The following is a description of a gene set: A better understanding of the molecular effects of aging in the brain may help to reveal important aspects of organismal aging, as well as processes that lead to age-related brain dysfunction. In this study, we have examined differences in gene expression in the hypothalamus and cortex of young and aged mice by using high-density oligonucleotide arrays. A number of key genes involved in neuronal structure and signaling are differentially expressed in both the aged hypothalamus and cortex, including synaptotagmin I, cAMP-dependent protein kinase C beta, apolipoprotein E, protein phosphatase 2A, and prostaglandin D. Misregulation of these proteins may contribute to age-related memory deficits and neurodegenerative diseases. In addition, many proteases that play essential roles in regulating neuropeptide metabolism, amyloid precursor protein processing, and neuronal apoptosis are up-regulated in the aged brain and likely contribute significantly to brain aging. Finally, a subset of these genes whose expression is affected by aging are oppositely affected by exposure of mice to an enriched environment, suggesting that these genes may play important roles in learning and memory. Human Gene Set: JIANG_AGING_CEREBRAL_CORTEX_DN Down-regulated in the cerebral cortex of aged (22 months) BALB/c mice, compared to young (2 months) controls species: Mus musculus from publication Jiang CH, Tsien JZ, Schultz PG, Hu Y (PMID 11172053), and this is the list of marker genes: ATP6V1E1, MGLL, DDX3X, TUBB4B, PTGDS, OAZ2, DYNC1H1, DAD1, PFN1, ACO2, NCL, EIF4G3, CPLX1, DNAJB11 (DnaJ heat shock protein family (Hsp40) member B11), HSP90AB1, NPTX1, EEF1G, ATP1B2, TIA1, PPP1CB, DNM1, NME1, DCTN1, CSDE1, KCNMA1, SKP1, PPP2CA (protein phosphatase 2 catalytic subunit alpha), CDK16, SEPTIN7, PPM1A, SRSF5, RAB14, NSF, ACTR3, ATP1A1, CSNK1A1, MAG, RAB2A, APOE, CCK, ATP6AP1, ARPP19, GABRA1, AP2M1, TUBB3, PLD3 (NCBI Gene Id 23646), CALM2, CS, SYT1